Given this list of marker genes PTGIS, NCOA1, PAQR3, ALOXE3, ASXL1, MED1, PPARA, FABP5, TWIST1, PDK3, HUWE1, ASXL2, FAM120B, PPARG, LEP, PLIN5, NCOA2, BMP2, ALOX15B, RXRA, MIR27B, GPS2, ALOX15, STUB1, CITED2, JUND, SIRT1, ACTN4, MIR34A, LMO3, here is a description of the gene set: species: Homo sapiens Human Gene Set: GOBP_PEROXISOME_PROLIFERATOR_ACTIVATED_RECEPTOR_SIGNALING_PATHWAY A nuclear receptor-mediated signaling pathway initiated by a ligand binding to an intracellular peroxisome proliferator activated receptor (alpha, beta or gamma) of the nuclear receptor protein family, and ending with regulation of a downstream cellular process, e.g. transcription.